Given this list of marker genes Oas1b, Ifi203-ps, Mphosph8, Ifitm3, Ifitm2, Bst2, Ilf3, Banf1, Ifi209, Oasl2, Srpk2, Ifnl3, N4bp1, Zc3hav1 (NCBI Gene Id 78781), Oas1g, Srpk1, Oas1d, Oas1c, Ifitm7, Mx2, Tnf, Trim28, Eif2ak2, Isg20, Rnasel, Ifi213, Oas1a, Isg15, Fam111a, Ifi207, Inpp5k, Ccl5, Morc2a, Ifi214, Shfl, Ifih1, Rsad2, Hmga2, Aicda, Tasor, Ifitm6, Ifi208, Slpi, Mavs, Oas2, Trim6, Ifi203, Oas3, Oas1h, Prox1, Mndal, Ifnb1, Ifi206, Plscr1, Morc2b, Ifitm1, Zfp809, Znfx1, Apobec3, Oas1e, Oasl1 (2'-5' oligoadenylate synthetase-like 1), Setdb1, Oas1f, Ltf, here is a description of the gene set: Mouse Gene Set: GOBP_NEGATIVE_REGULATION_OF_VIRAL_GENOME_REPLICATION Any process that stops, prevents, or reduces the frequency, rate or extent of viral genome replication. species: Mus musculus